Given this list of marker genes MDM2, TSPAN31, IGF2, PIM1, XK, RFC5, VBP1, PRKCA, MCF2, CCNG1, CDK1, GLRX, SMAD4, CDKN3, CASP10, TFAM, PRKCD, XRCC6, CDC25A, RNF5 (NCBI Gene Id 6048), POR, RAP1A, PFDN4, RFC4, NEK6 (NCBI Gene Id 58167), CDKN2A, NDUFAB1, CCN3 (cellular communication network factor 3), GAP43, CCNF, GTF2IP4, here is a description of the gene set: Arsenic compounds are widely distributed and arsenic ingestion is associated with many human diseases, including blackfoot disease, atherosclerosis, and cancers. However, the underlying mechanism of arsenic toxicity is not understood. In human fibroblast cells (HFW), arsenite is known to induce oxidative damage, chromosome aberrations, cell cycle arrest, and aneuploidy, and the manifestation of these cellular responses is dependent on changes in gene expression which can be analyzed using the cDNA microarray technique. In this study, cDNA microarray membranes with 568 human genes were used to examine mRNA profile changes in HFW cells treated for 0 to 24 h with 5 microM sodium arsenite. On the basis of the mean value for three independent experiments, 133 target genes were selected for a 2 x 3 self-organizing map cluster analysis; 94 were found to be induced by arsenite treatment, whereas 39 were repressed. These genes were categorized as signal transduction, transcriptional regulation, cell cycle control, stress responses, proteolytic enzymes, and miscellaneous. Significant changes in the signaling-related and transcriptional regulation genes indicated that arsenite induces complex toxicopathological injury. Genes in cluster 3: delayed up-regulation in HFW cells (fibroblast) by sodium arsenite. studied in species Homo sapiens from publication Yih LH, Peck K, Lee TC (PMID 12016162) Human Gene Set: YIH_RESPONSE_TO_ARSENITE_C3